Given this list of marker genes SLC30A8, SLC30A1, SLC30A3 (solute carrier family 30 member 3), SLC30A2, SLC30A5 (NCBI Gene Id 79021), here is a description of the gene set: Reactome Pathway: Zinc efflux and compartmentalization by the SLC30 family The human SLC30 gene family of solute carriers is thought to participate in the homeostasis of zinc ions and facilitate zinc transport into specialized compartments of the cell such as endosomes, golgi network and synaptic vesicles. There are 10 members of this family, named ZnT1-10. ZnT4, ZnT9 and ZnT10 have no function determined as of yet (Palmiter RD and Huang L, 2004). part of: Zinc transporters studied in species Homo sapiens